Given this list of marker genes Slurp1, Nrg3, Jag1, Pin1, Ccl21f, Rras, Padi2, Tgfbr3, Tgfbr1, Cnn2, Svbp, Gtpbp4 (NCBI Gene Id 85330), Ngfr, Ptpn23, Ptk2, Adamts9, Cldn5, Erdr1, Stc1, Ripor2, Bst2, Muc2, Pkp2, Il24, Abhd2, Dusp1, Lrch1, Dusp3, Nbl1, Jup, Apoh, Ifitm1, Emilin1 (elastin microfibril interfacer 1), Cdh1, Hoxa7, Angpt2, Bmerb1, Apoe, Arhgdia, Rin3, Acvrl1, Wasl, Cx3cl1, Wnt4 (NCBI Gene Id 22417), Atp2b4, St6gal1, Reck, Srf, Gm266, Frmd5, Epha1, Cd74, Cdh11, Adgrg1, Rbbp7, Krt16, Tet1, Gnrh1, Cd300a, Hmgb1, Ptpn2 (protein tyrosine phosphatase, non-receptor type 2), Tacstd2, Ccl12, Gdf15 (NCBI Gene Id 23886), Klf4, Drd4, Stat3, Chrd, S2bpcox16, Adipoq, Ccl28, Timp1, Ppard, Bcl2, Hyal2, Hc, Ptgr1, Nedd9, Ndrg4, Clasp2, Dag1, Igfbp3, Dab2ip, Cldn19, Srgap2, Ryk, Pdcd10, Adora3, Atp1b2, Nfe2l2, Dach1, Ptprt, Slit2, Dcn, Sap30l, Dusp22 (NCBI Gene Id 68676), Adam15, Mia3, Arhgdib, Stard13, Adgrb1, Ghrl (ghrelin), Arid4a, Ctnna1, Mitf, Cxcl12, Myocd, Magi2, Adtrp, Trib1, Wnt3a, Adarb1, Apod, Cx3cr1, Suds3, Ptprj, Pten, Ptprr, Eppin, Bmp10, Fignl2, Mapk15 (mitogen-activated protein kinase 15), Rap2b, Ptpru, Dll4, Arrdc3, Adora1, Zeb2, Cyp1b1, Cav1, Abhd6, Trp53inp1, Il1rn, Sema3a, Rac1, Sin3b, Miip, Pdgfb, Nav3, Mecp2, Arhgap4, Ghsr, Ccl21e, Nisch, Plxnb3, Synj2bp, Nr2f2, Dsg3, Srgap1, Cited2, Col3a1 (collagen, type III, alpha 1), Idh2, Wnt5a (wingless-type MMTV integration site family, member 5A), Coro1b, Apex1, Tcaf1, Lrp1, Dpp4, Eng, Dnaja4, Crk, Rgcc (regulator of cell cycle), Tafa5 (TAFA chemokine like family member 5), Tmeff2, Gdf2, Clasp1, Nkx2-1, Braf, Map2k5, Nexmif, Pik3r2, Cd69, Aif1, Tie1, Nrg1, Gata3, Spred1, Il33, Rabgef1, Abr, Brms1, Wfdc6b, Ldlrad4, Sap30, Epha4, Cfl1, Card10, Tnfaip6 (tumor necrosis factor alpha induced protein 6), Stk26, Foxo3, Ptprm, Csnk2b, Cers2, Prkg1, Tmem196, Nrp1, Ccl25 (C-C motif chemokine ligand 25), Sema5a, Egfl7 (EGF-like domain 7), Calr, Serpinf1, Igfbp5, Mcc, Tnn, Cldn3, Prl7d1, Krit1, Ada, Dlg5, Ing1, Coro1c, Robo2, Podn, Stk24, Rap2a, Slamf8, Cd63, Kiss1r, Klrk1, Arid4b, Sin3a, Brms1l, Ccl21b, Evl, Sema3f, Nherf1, Rnf20, Tbx5, S1pr2, Dbn1, Robo1, Mif, Scai, Kank1, Bmpr1a, Pin1rt1, Drd2, Macir, Marveld3, Srgap3, Tbxa2r, Hdac2, Ppargc1a, Nodal, Thbs1, Fas, Itgb1bp1, Cd200, Hdac6, Slit1, Sinhcaf, Serpine1, Ccn3, Mctp1, Plxna3, Rhob, Hdac1, Bcr, Notch1, Nf1, Ccdc125, Gcsam, Meox2, Ogt, Ccl21a, Grem1, Il27ra, Sfrp2, Tpm1, Cyp19a1, Hdac5, Tnf, Phldb2, Dpysl3, Patz1, Ilk, Park7, Adipor1, Gna13, Vash1, Hnf4a, Ifnb1, Tmigd3, Cygb, Drd5, Dlc1, Cxcl13, Pparg, Arpin, Stap1, Ptn, Kiss1, Il4, Wfdc6a, Fbln1, Emilin2, Ing2, Pip5kl1, Gsk3b, Robo4, Abcc8, Gpr18, Arid2, Dpep1, Gna12, Limch1, Drd1, C5ar2, Adipor2, Rhoa, Osbpl8 (oxysterol binding protein-like 8), Ptprg, Spint2, Plcb1, Dusp10, Dnai3, Fgf2, Afdn, Gadd45a, Sulf1, Hrg, Shh, Mmrn2, Eppk1, Wnt11, Ap1ar, Ptprk, Acvr1c, Rbbp4, Fuz, Sp100 (NCBI Gene Id 20684), Sfrp1, Angpt4, Nog, Ptger4, Mmrn1, Myh9, Gstp1, Sema6d, Gstp2, Clic4, Was (Wiskott-Aldrich syndrome), Has1, Mmp28, Gja1, Ptpn1, Akt1, Zmynd8, Ccl21d, Rap2c, Acan, Cd200r1, Gpr173, Rnf41, Mef2c, Wnt3, Ager, Pfn2, Sap130, Tgfb1, Rgn, Thy1, here is a description of the gene set: studied in species Mus musculus Mouse Gene Set: GOBP_NEGATIVE_REGULATION_OF_LOCOMOTION Any process that stops, prevents, or reduces the frequency, rate or extent of locomotion of a cell or organism.